The following is a description of a gene set: The set of thin, flattened membrane-bounded compartments, called cisternae, that form the central portion of the Golgi complex. The stack usually comprises cis, medial, and trans cisternae; the cis- and trans-Golgi networks are not considered part of the stack. studied in species Homo sapiens Human Gene Set: GOCC_GOLGI_STACK, and this is the list of marker genes: B4GALT6, TRAPPC4, MGAT2, FUT5, HACE1, GALNT3, CHPF2, ST3GAL1, B4GALNT3, GOLGA8DP, NAGPA, GOLGA8S, CHSY1, MGAT4B, MARCHF4, SORL1, GALNT2, GAL3ST3, GOLGA3, PITPNM1, YIPF6, TMEM115, SCFD1, RAB34, NECAB3 (NCBI Gene Id 63941), SAR1A, GOLPH3L, INPP5E, A3GALT2 (alpha 1,3-galactosyltransferase 2), GBF1, GPR89B, GOLGA8A, GOLIM4, B4GALT3, MAN2A1, SORT1, TMBIM4 (NCBI Gene Id 51643), ARSL, LYPLA2, GPR89A, GOLGA7, GOLGB1, FUT3, USO1, GOLGA8K (NCBI Gene Id 653125), FUT6, GOLGA6C, GOLGA8M (NCBI Gene Id 653720), GOLGA8CP, VCPIP1 (valosin containing protein interacting protein 1), GOSR1, ABO (ABO, alpha 1-3-N-acetylgalactosaminyltransferase and alpha 1-3-galactosyltransferase), GOLGA5, GOLGA8Q, GOLGA8IP, ATP2C1, RAB14, MARCHF9, GOLGA6B, ATL1, CHPF, B4GALT7, GAL3ST2, FUT4, GOLPH3, SLC30A5, RAB30, LYSET, GOLGA8J, TMED2, B4GALT2, CLIP3, CSGALNACT2, OCRL, GGTA1, MBTPS1, MGAT4D, GCNT1, GOLGA8H, B4GALNT4, GALNT1, RAB21, SAR1B, CANT1, ZFYVE1, ST6GAL2, AKAP9, GOLGA8T, GOLGA8R, TMEM87A, SLC30A7, CHSY3, COG3, TMEM87B, TMEM59, YIPF2, FUT1, GAL3ST4, ACP3, PSENEN, GOLGA8O, DNMBP, FUT8, SULF2, LLGL1, RAB27B, MOB4, COG2, RASIP1, ST6GAL1, PLK3, GOLGA8B, NSFL1C, GCC1, FUT7, APH1A, GOLGA6D, ZDHHC14, GOLT1A, STX16, SGMS1 (sphingomyelin synthase 1), LPCAT2, ST3GAL2, B4GALT5, NSG2, B4GALT1 (NCBI Gene Id 2683), ASAP2, BCAP31, CSGALNACT1, SULF1, ST3GAL4, VRK1, XYLT1, FUT2, GOLGA8N, SMPD3, GOLGA6A, MGAT4A, GOLGA2, CLN3, NSG1, HID1, ARAP1, B3GALT6, YIPF1, BET1L, NSF, ST3GAL3, HLA-A, TMED3, TOM1L1, UXS1